Given this list of marker genes SLC26A2, FGF9, SALL1, FBLN1, MAP3K20, HOXD13, POR, SMOC1 (SPARC related modular calcium binding 1), here is a description of the gene set: Metatarsal synostosis studied in species Homo sapiens Human Gene Set: HP_METATARSAL_SYNOSTOSIS